The following is a description of a gene set: studied in species Homo sapiens The directed movement of tricarboxylic acids into, out of or within a cell, or between cells, by means of some agent such as a transporter or pore. Human Gene Set: GOBP_TRICARBOXYLIC_ACID_TRANSPORT, and this is the list of marker genes: UMOD, SFXN5, SLC13A5, SLC13A3, SLC25A1